Given this list of marker genes CLOCK, MTCL2, SLC37A3, ACSL1, LGR4, CACNA1E, KITLG, PNOC, CELF3, SLC27A4, HTR2C, VCL, GPR22, FOXP1, SNAI1, MBLAC1, S1PR3, TSN, GREM2, RFX3, FGD6, CERS6, SRPRA, KIAA1217 (KIAA1217), BRPF3, WASF1, DAAM1, ASB1 (ankyrin repeat and SOCS box containing 1), STRN3, NPNT, PTGIS, DIXDC1, ADD2, PPARGC1B, TAF4B, LILRA1, PKP4, FAM117B, FRMD5, RPS6KL1, GALNT7, VAMP2, XBP1, UBP1, PPP1R16B, STAB2, MYT1, FAM76A, KDM5D, RTN4RL1, SEPTIN3 (septin 3), JADE2, EML5, NRN1, MEX3C, BNC2, CUEDC1, FKBP1B, ACSL4, CTNND2 (NCBI Gene Id 1501), RPGRIP1L, NAV1, EPS15L1, UHRF2, ZMYND11, RPS6KA4, CA7, RRAS, ANKS1A, TMEM200B, CBFA2T3, JAKMIP1, MET, SIDT2, SLC25A27, FUT9, SUCO, SERPINF2, METAP1, KLF4, SCN2B, ANK2, LHX2, PLAG1, GMNC, PGM1, DLL1, DNM1L, OSGIN2, LMAN1, CPLX2, GABRA3, RALGPS1, CDK6, GPR158, LYST, TMEM74, SGPP1, ZDHHC17, ADO, SHKBP1, TANC2, INA, CDH13, SLC4A7, PEA15, MLLT1, PDE7B, RGS17, DNAJC16, SNTB2, TGIF2, TASOR, BRINP1, PURB, RAP1GDS1, SATB2, FRA10AC1, MAP2K1, SFT2D1, CYREN (NCBI Gene Id 78996), ASIC2, TENT5A, PACS1, ZFHX4, DPYSL4, TBL1XR1, NRIP3, SNX9, ARHGAP26, ARHGAP1, CAMTA1, C14orf28, ADIPOR2, DCAF7, NOS1AP, LDHA, GOLPH3L (NCBI Gene Id 94793), IGF2BP3, IL6R, SMIM15, CACNA1C, MCIDAS, OAZ2, NUMBL, FOXN2, CLCN3, TMEM109, SNX15, FLOT2, ZBTB9 (NCBI Gene Id 221504), RAD9B, PPP2R3A, MGAT4A, NAV3, MYH9, TAF5, SYT1, RTL6, PDXK, MGAT5B, TOB2 (transducer of ERBB2, 2), NECTIN1 (NCBI Gene Id 84853), AKIP1, FUT8, TPPP, ANKRD52, FOXJ2, ADAM22 (NCBI Gene Id 53616), PITPNC1, FAM83A, CBX3, ACBD3, MYCN, HCN3, MDM4, AHCYL2, FGF23, PPFIA1, E2F3, ZNF281, NCEH1, UNC13C, ZBTB20, PPP1R11, E2F5, XYLT1, TRIM67, ARID4B, MPP2, ZMYM4, LMAN2L, XPO5, SYNJ1, SHISA7, NOTCH2, TPD52, MTMR10, ZNF304, RELN, TMEM255A, JAG1, PDGFRA, SDK2, OLIG3, STK38L, MAP7D3, TPCN2, PLOD1 (procollagen-lysine,2-oxoglutarate 5-dioxygenase 1), HNF4A, GLCE, ASB4, BMP3, PLEKHH2, DGKZ, DAGLA, TNRC18, GP5, ZDHHC16, ATMIN, ERGIC1, AGO4, CACNB3, RCAN1, POGZ, ZYG11B, STX17, FBXO30, LEF1, SHOC2, ANK3, ELMOD1, NOTCH1, HSPA1B, TMEM184B, RRAGC (Ras related GTP binding C), GMFB, BCL2L13, ABR, ZNF644, CNOT6, TMEM164, SLC44A2, FAM167A, ZNF551, SEMA4B, AXL, PPP1R10, UCN2, MLLT3, AMER1, DPP3, TRANK1 (NCBI Gene Id 9881), CCNE2, SAR1A, KCNK3, CREB3L2, RDH11, here is a description of the gene set: from publication Chen Y, Wang X (PMID 31504780) species: Homo sapiens Genes predicted to be targets of miRBase v22 microRNA hsa-miR-34c-5p in miRDB v6.0 with MirTarget v4 prediction scores > 80 (high confidence targets). Human Gene Set: MIR34C_5P